Given this list of marker genes ZNF677, TTC23L, WWTR1, DAP, PAX6, RASL11A, C1orf53, TGFB2, WSCD2, ADAM12, CDCA2, SHH (NCBI Gene Id 6469), ALX4, SIAH3, FOXF1, RPS27L, ZNF566, GATA3, here is a description of the gene set: species: Homo sapiens Genes identified as hypermethylated in SW48 cells (colon cancer). Human Gene Set: WEBER_METHYLATED_IN_COLON_CANCER from publication Weber M, Davies JJ, Wittig D, Oakeley EJ, Haase M, Lam WL, Schübeler D (PMID 16007088) Cytosine methylation is required for mammalian development and is often perturbed in human cancer. To determine how this epigenetic modification is distributed in the genomes of primary and transformed cells, we used an immunocapturing approach followed by DNA microarray analysis to generate methylation profiles of all human chromosomes at 80-kb resolution and for a large set of CpG islands. In primary cells we identified broad genomic regions of differential methylation with higher levels in gene-rich neighborhoods. Female and male cells had indistinguishable profiles for autosomes but differences on the X chromosome. The inactive X chromosome (Xi) was hypermethylated at only a subset of gene-rich regions and, unexpectedly, overall hypomethylated relative to its active counterpart. The chromosomal methylation profile of transformed cells was similar to that of primary cells. Nevertheless, we detected large genomic segments with hypomethylation in the transformed cell residing in gene-poor areas. Furthermore, analysis of 6,000 CpG islands showed that only a small set of promoters was methylated differentially, suggesting that aberrant methylation of CpG island promoters in malignancy might be less frequent than previously hypothesized.